Given this list of marker genes Itgav, Cacna1a, Ghitm, Trpv1, Itpr1, Crisp4, Pkdrej, Trpc5, Grm3, Cacnb1, Trpv4, Orai3, Tmbim6, Ryr3, Slc8a1, Slc8b1, Micu3, Rem1, Cachd1, Tmc1, Nrxn1, Tpcn1, Cacnb4, Htr1b, Calhm1, Cacng1, Cacna1b, Micu2, Cacna2d4, Cacna1d, Grin2a, Grik2, Mcub, Mcoln2, Slc24a2, Cnga2, Grm2, Pacsin3, Orai1, Trpc6, Cacna1i, Trpc1, Gnb2, Cabp5, Hrh1, Atp2b4, Tmbim7, Ano9, Atp2c1, Trpa1, Cabp4, Atp13a4, Anxa5, Trpm2, Catsper1, Cacng6, Tmbim1, Cacng7, Micu1, Fkbp1b, Trpc3, Nalf1, Nalf2, Grina, Cacng4, Pkd1l1, Trpm8, Tmem37, Cnga3, Scnn1a, Pkd1l2, Slc30a1, Orai2 (NCBI Gene Id 677007), Grm7, Cabp1 (calcium binding protein 1), Gria1, Atp2a2, Nrxn3, Tmem165, Tspan13, Mcu, Gria3, Atp2b2, Trpv5, Pkd1, Cnga1, Tmc2, Atp2a3, Hpcal4, Mcoln1, Panx1, Rrad, Catsper4, Tspoap1, Cacna2d3, Tpcn2, Rimbp2, Pkd1l3, Cacna1g, Cacna1e, Grin2c, Stimate, Calm3, Catsper2, Pkd2l1, Grin2b, Pkd2, P2rx1, Calm2, Tmbim4 (transmembrane BAX inhibitor motif containing 4), Cacng5, Grin3b, Ryr2, Atp2b3, Catsper3, Slc24a5, Scnn1b, Nrxn2, Phpt1, Grin1, Itpr3, Slc30a10, Ryr1, Trpc7, Slc8a3, Trpm1, Calm1, Cacna2d1, Letm1, Itpr2, Pkd2l2, Trpm4, Trpm3, Bnip1 (BCL2/adenovirus E1B interacting protein 1), Trpm6, Grik3, Prkg1, Slc24a4, Cav3, Trpc2, Rasa3, Slc24a3, Cacna1s, Tnni3, Scnn1g, Faim2, Pde4d, Trpm7, Trpv2, Tmco1, Cacna2d2, Panx3, Cacna1f, P2rx4, Mcoln3, Gem, Stx1a, Cacna1c, Cacnb3, Grin2d, Cacna1h, Prkcb, Gpm6a, Ywhae, Stim1 (stromal interaction molecule 1), Ncs1, Trpv6, Trpv3 (NCBI Gene Id 68700), Calhm3, Slc24a1, Cacng2, Sec61a1, Atp2a1, Psen1, Cacnb2, Grin3a, Atp2c2, Cacng8, Cacng3, Cabp2, Grik1, Stim2, Atp2b1, Oprm1, Trpc4, Slc8a2, Rem2, here is a description of the gene set: Enables the transfer of calcium (Ca) ions from one side of a membrane to the other. Mouse Gene Set: GOMF_CALCIUM_ION_TRANSMEMBRANE_TRANSPORTER_ACTIVITY studied in species Mus musculus